Given this list of marker genes MT2A, INTS12, IFIT5, WARS1, RIGI, PDGFRL, SERPING1, IFI44L, PTPRS, KPNA5, AGAP2, CNP, SELENOI, ERRFI1, PSCA, TRIM21, TAF5LP1, IFIT2, TENT4A, GTPBP2, ARL5B, RNF213, PDE6A, TRIM31, SLC31A2, APOL6, PNPT1, GRIP2, ZBED1 (NCBI Gene Id 9189), DDX60L, RTP4, GRHL1, MAML2, FAM135A, BCL6B, NT5C3A, SP140L, SLCO3A1, IFIT1, CMPK2, PIWIL4, DTX3L, ADAR, PAPOLG, IKBKE, MX1, MYBL1, PHOX2B, ZNF618, HERC6, STARD5, EPSTI1, IL15, SRC, MOV10 (Mov10 RNA helicase), TAP1, ZBP1, ISG15, PARP14, CD274, OAS2, USP42, CXCL10, RNF144B, IFITM3, NAMPT, CSRNP1, OAS3, IFNL1, SEZ6L2, MASTL, PARP12, TNF (NCBI Gene Id 7124), MAK, CDH11, PML, CCL8, UBE2L6, ANKFY1, CXCL11, SP140, TRIM25, NINJ1, HELZ2, RSAD2, TMEM268, TRIM5, PPP4R1L, NPPA, USP18, BRIP1, PMAIP1, GBP4, PARP9, APOBEC3G, NLRC5, SIGLEC1, ETV7, TRIM56 (tripartite motif containing 56), RAD9A, PATL1, IFI6, HK2, XCR1, CARINH, OASL, IFIT3, AZIN2, DDIT4, MYD88, IRF7, ZNFX1, MIR924HG, TGM1, SMCHD1, STAT2, IFNA1, SERPINB9P1, XAF1, USPL1, DMRTB1, SEMA4D, CD80, MKLN1, IFI44, DDIT3, IDO1 (indoleamine 2,3-dioxygenase 1), AIM2, BCL3, PLSCR1, GBP1, SHFL, RTCB, JOSD2, APOL1, KCNK15-AS1, GBX1, NEXN, DUSP5, SLFN5, CXCL9, TNFSF10, IFNL2, SECTM1, AMOTL2, PCDHB16, GBP5, ISG20, ATP2B3, NCOA7, PTGS2, IRF1, CMTR1, SAMD9L, PI4K2B, CFB, UCA1, CASP10, ARHGEF11, TSSK4, PPM1K, GCM1, PELO, DHX58, TMEM217, ITIH4, FUT11, BATF2, HPCAL4, IFNB1, GAD1, DDX60, STX17, SBK1, SAMD9, SELENOO, GADD45B, CNIH2, GCH1 (NCBI Gene Id 93984), TENT5A, UNC13A, LGALS3BP, ZBTB43, TMEM140, TRIM22, SERPINA4, IFIH1, PHF11, HERC5, TGFB2, SP110, MX2, TLK2, PTK2B, CLK1, GPR180, here is a description of the gene set: The dendritic cell (DC) is a master regulator of immune responses. Pathogenic viruses subvert normal immune function in DCs through the expression of immune antagonists. Understanding how these antagonists interact with the host immune system requires knowledge of the underlying genetic regulatory network that operates during an uninhibited antiviral response. In order to isolate and identify this network, we studied DCs infected with Newcastle Disease Virus (NDV), which is able to stimulate innate immunity and DC maturation through activation of RIG-I signaling, but lacks the ability to evade the human interferon response. To analyze this experimental model, we developed a new approach integrating genome-wide expression kinetics and time-dependent promoter analysis. We found that the genetic program underlying the antiviral cell state transition during the first 18-hours post-infection could be explained by a single regulatory network. Gene expression changes were driven by a step-wise multi-factor cascading control mechanism, where the specific transcription factors controlling expression changed over time. Within this network, most individual genes are regulated by multiple factors, indicating robustness against virus-encoded immune evasion genes. In addition to effectively recapitulating current biological knowledge, we predicted, and validated experimentally, antiviral roles for several novel transcription factors. More generally, our results show how a genetic program can be temporally controlled through a single regulatory network to achieve the large-scale genetic reprogramming characteristic of cell state transitions. Human Gene Set: GSE18791_CTRL_VS_NEWCASTLE_VIRUS_DC_8H_DN from publication Zaslavsky E, Hershberg U, Seto J, Pham AM, Marquez S, Duke JL, Wetmur JG, Tenoever BR, Sealfon SC, Kleinstein SH (PMID 20164420) Genes down-regulated in comparison of control conventional dendritic cells (cDC) at 0 h versus cDCs infected with Newcastle disease virus (NDV) at 8 h. studied in species Homo sapiens